The following is a description of a gene set: studied in species Homo sapiens Genes containing one or more binding sites for (PRKDC) in their promoter regions (TSS -1000,+100 bp) as identified by GTRD version 20.06 ChIP-seq harmonization. from publication Yevshin I, Sharipov R, Kolmykov S, Kondrakhin Y, Kolpakov F (PMID 30445619) Human Gene Set: PRKDC_TARGET_GENES, and this is the list of marker genes: TCP11, LRPPRC, ATF7-NPFF, TARS2, MAF1, AKAP13 (A-kinase anchoring protein 13), STT3A, POLRMT (RNA polymerase mitochondrial), RGMB, OXSR1, RBM15, APTR, SHFL, PPFIBP1, ABCA7, AGPAT1, PTMA, SLC29A3, GYS1, PMF1-BGLAP, SLF2, ZNF77, NRL, DERL2, PLEKHH2, UNG, RAB40B, MPHOSPH8, IVD, DDX19B, ZNF726, ENSG00000275740, AXL, PROSER3, MON1B, EIF4A1, SP3, XPO1, HDAC11-AS1, FUT8, PNKD, ZDHHC12, PRR13, ZNF486, CREB3L3, MYH9, CDC23, DNAL4, SCAMP2, SLC25A42, MTHFD1, GLCE, NR3C2, AAMP, PC, DHRS3, PLCL1, GLCCI1, LMAN2, ZFHX3-AS1, HDGFL2, ZNF714, DOHH, WBP1, AMER1, UFD1-AS1, STPG1, PHTF2, SPAG7, CEP44, HDAC4 (histone deacetylase 4), ARHGEF9, METTL14, BAZ1B, PHYHIP, FKBP3, HNRNPUL1, EIF1AY, MIR6860, DBI, HEXIM2, SRPK1, TEPSIN, PHF14, SIX2, ZNF200, AP3M2, STXBP5-AS1, SRP19, MTOR, RNF5, LMBR1L, ZNF564, CDK5R2, MTRFR, DCAF15, TMEM53 (NCBI Gene Id 79639), NIPAL3, DCAF7, LINC02210, NLRP1, ZRANB3, HNRNPAB, UBFD1, TPM4, C22orf39, SLC39A1, PTPRM, MEGF9, FAM161A, DRC3, RAB8A, TOP2B, KDM2B, DRC12, DNAI3, ACTL6A, SUFU, ZBTB20, KDM6A, CIRBP, HSPA5-DT, ETV5, NAXD, PITX2, IL11RA, ANAPC5, SUN2, AHI1, WBP1L, CREBRF, TRAF2, TSACC, ZNF678, ANKZF1, PMEL, PDIA6, ERAP1, CEP57, MED7, METTL14-DT, LENG1, ID2, CYTH2, PMS1, TDRKH, THAP3, ZNF211, RAB11B-AS1, ORMDL1, SETD1A, MRTFA, ZNF423, NGDN, ANKHD1-DT, JPT1, ZNF687, TRPS1, C3orf18, VAMP1, ZNF587B, NLRX1 (NCBI Gene Id 79671), CCNB2 (cyclin B2), NOL4L-DT, STX5-DT, FYN, PER1, RELCH, NR6A1, ENSG00000255647, CHCHD2, GNAS-AS1, ZNF141, PPP2R5E, DOC2A, RFWD3, XAB2, EPB41, HGH1, HIRA, NFYC, PANK2-AS1, ANKRD11, SNX12, TMEM45A, LINC01972, ZMYM5, GLRX5, ZC3H6, TRIM9, CCT7, GATAD2A, IER5L, TRAFD1, BRPF3-AS1, CLSTN3, MTMR12, ADAMTS4, IRF2BP1, HSPB6, C10orf143, CCDC137, ZNF436-AS1, CDC25A, UBP1, ARHGEF1, DNAJB5-DT, DLGAP5, ZMYM2, NUP98, ACOT8, RNF34, SNHG10, FLAD1 (flavin adenine dinucleotide synthetase 1), SLC28A2-AS1, MACROD2, PRPF40A, SORT1, H2AZ2-DT, OSBPL3, PCNX3, DNAJC27-AS1, SPRYD3, PRR11, ABHD8, C5orf22, STIP1, PAF1 (NCBI Gene Id 54623), AFG2B, ZNF687-AS1, COQ7-DT, SNRNP25, LAPTM4A-DT (LAPTM4A divergent transcript), SWSAP1, PTPN1, TTC23, MEX3C, ZNF691-DT, ZNF174, GLS2, CDK2AP2, ZNF790-AS1, HSPA2-AS1, CDK16, RHPN1-AS1, ZNF626, SMIM2-AS1, ENSG00000261335, RUVBL1, OTUD5, ZNF493, KATNAL2, ZNF833P, YIF1A, AASDHPPT, PXMP4, RPL6, CAPSL, R3HDM1, ABHD2, EMC9, OTUB2, USF3, CEP89, NDUFA3, EFCAB11, COPE, BPGM, SPG7, HAPSTR1 (NCBI Gene Id 29035), TMEM60, LINC00642 (long intergenic non-protein coding RNA 642), CNOT1, GTF3C1, PGPEP1, CARS2, RPN2 (ribophorin II), TNRC6B, SNORD60, PDLIM4, HIBADH (3-hydroxyisobutyrate dehydrogenase), AKTIP, WBP11, KDM4B, H1-12P, ZSCAN20, HNRNPK, MAF, PPP1R13L, PRADC1 (protease associated domain containing 1), CDR2-DT, PPM1K-DT, FRMD5, GRB2, PDP2, RTTN, ARAF, JUP, OSBPL2, TMTC4, CREB3L2, ORC2, DCUN1D4, CBX5, GUCY1B1, UBE2C, ZDHHC9, PLEKHA8, SRXN1, AK2, COQ7, CHD8, TMX2, SERTAD2, DCAF4, ERCC1, SRGAP2C, LINC01535, H2AZ2, FAM117A, RPL18A, RAB11B, PCDH10-DT, KLHL25, SEL1L2, INMT, LTN1, GET3, UPRT (NCBI Gene Id 139596), CRYZL1, ATP6AP2, C12orf60 (NCBI Gene Id 144608), GPR158, PPP3CA, INCENP, GTPBP1, KCTD9, NCK1-DT, CCDC8, RBM27, C1QTNF6, CASTOR1, LINC00665, HNRNPLL, PWWP2A (PWWP domain containing 2A), COPZ1, PET100, ZNF799, ZDHHC5, EIF2AK3-DT, ZBTB3, STARD3NL, SP1, SLC37A4, LMTK2 (NCBI Gene Id 22853), UGP2, ZNF519, ZNF680, ANKS3, GOLIM4, SKA2, STAT3, SEC14L2, ZBTB38, PACSIN2, ZNF431, LRRC74B, SCAI, KMT5C, BCL2L1 (BCL2 like 1), MAP3K3, TCP1, ANKRD54, ALKBH7, SLC15A4, LCMT1-AS1, PLAC9P1, AMD1, NAIF1, NONO, YJU2, PRMT1, TRIM45, ENO1-AS1, ARMC6, MIR4479, ZNF691, HYCC1, ZNF875, SARNP, PABPN1, BUB3, ZNF154, C19orf81, DCAKD, PDXP-DT, BRCA1, TANGO2, TMEM160, SIRT1, TYW1B, ENSG00000275765, MFRP, NUMB, CANX, ZBTB7B, MIR638, HACL1 (2-hydroxyacyl-CoA lyase 1), SEPTIN9, ARMH1, RPS6KA5, ZDHHC24 (zinc finger DHHC-type containing 24), ZNF823, FAAP24, PER2, GATM, TESK2, ZNF443, ZNF143, DCAF11, TDRKH-AS1, ACTN3, PTPN11P3, RPLP0, CCDC61, ZNF682, FICD, SLFN5, SHKBP1, APBA3, COPS7B, FAM72B, RGMB-AS1, UBE2S, ZNF774, ENSG00000255240, KIF1B, PRPF8, CHAF1A (chromatin assembly factor 1 subunit A), PGAP2, HSPA2, TTLL5, KRT15, SLC46A3, OIP5-AS1, BCKDHA, PJA2, GNA15-DT, SNHG19, EIF2AK3, TOMM40L, MED29, ATP6AP1-DT, ENSG00000257732, GOLPH3L, RHCE (NCBI Gene Id 652552), FRYL, ZNF66, ITFG2, RNF20, PCP4L1 (NCBI Gene Id 654790), INPP5B, NMT1 (N-myristoyltransferase 1), SDC2, DNAJC14, MLH1, SEMA4B, MYH9-DT, GADD45B, ELN-AS1, TPCN1, VSTM2L, TRAF7, ZNF587, TBC1D10B, MYH10, CFAP157, TINAGL1, MYL11, C2orf76, BTD, SAMTOR (S-adenosylmethionine sensor upstream of mTORC1), FAM83D, ZNF776, HRAS, CREB3L4, LCMT1, HLTF, CYB5A, SNX32, VBP1, ABCB8, TSPAN15, ZNF788P, CNOT3, ERC2, BCAS3, ZNF442, CCT3, DDX39A, PLIN3, SLC2A1-DT, SLC41A1, UVRAG, ZNF44, SAFB, ANKRD27, ZNF695, P2RX6P, RAB5C, FKBP14, GPR108, C7orf50, ARVCF, ADGRB2, COQ8B, ZNF436, TLCD5, MSANTD4, INHBE, ATP5F1B, ANAPC15, ANKHD1, HSPA5, RAB3A, HMGN5, LINC02210-CRHR1, SSR4, STX7 (syntaxin 7), MRPL37, CAND1, DCTN4, CETN4P, KHSRP, KANK3, DNAAF8, KCNAB2, JPT2, ZFYVE21, ZC2HC1C (NCBI Gene Id 79696), LINC01572, ANKRD16, HNRNPA1, COPS4, ZNF91, KMT5A, TMEM161A, FBH1, PNPLA6, PSMB3, THUMPD3-AS1, CYP2R1, EARS2, RAB5B, PLCD1, ANP32E, INMT-MINDY4 (NCBI Gene Id 100526825), DAPK3, RSBN1L, SLC2A1 (NCBI Gene Id 6513), GDI2, NUBP2, H2AJ, OS9, TLE4, ING1, EIF1, KAT6B, ST6GALNAC6, PANK2, ITSN1 (intersectin 1), ITFG2-AS1, ABCD3, PDZD7, ID2-AS1, SFPQ, PRC1, GNAI2, MED30, ELMO2, YBX1, HDAC4-AS1, SETD5, CIC, TRAPPC11, SLC2A8, DROSHA, MDC1, ZNF654, ZNF718, HBP1, ACTR2, PDLIM7, IQCD, RGS9BP, DIAPH3, HDAC11, MTFR2, RSPH4A, RNU2-17P, XRCC3, ATF7, DNM2, CCNL2, ARL17B, FBXO24, ARID3A, OXR1, CHASERR, RELB, TCERG1, ORMDL2, HNRNPC, COX6B1, TCF3, BBS12, PLS3, EHBP1, ANP32A, GOT1-DT, NDUFAF8, ZNF143-AS1, ENSG00000224478, PXN-AS1, ZNF492, SSBP3, ENSG00000254531, TMEM198B, ASXL1, TMEM9, ATP6AP1, WDR45, PRKACA, EVI5L, KANTR, ALKBH5, SELENOI, MECP2, ARHGAP19, CCR10, HEXIM2-AS1, CDCA3, PIGN, SLC25A25, ERCC2, MSMO1, PDXP, ZNF441 (NCBI Gene Id 126068), ZSWIM1, SCAND2P, ENSG00000227218, PCLAF, MGRN1, MED19, PPM1B, TRIP10, ORC6, ZNF418, TCTN3, FAM76B, TOM1L2, STARD5, ABCA11P, RTN4, DYNLRB1, OXLD1, RFX2, NRXN2, DHX38, RNF6, PPP2R5A, WHAMM, FGD5-AS1, LINC00654, NFE2L1-DT, NCOA2 (nuclear receptor coactivator 2), GBF1, EPM2AIP1, ORAI3, ZNF732, ESR2, PDE6D, DNAJB5, NF2, EIF5 (NCBI Gene Id 1983), TUBB4B, RMI1, CETN3, VPS35, ADAMTSL4, HS3ST3B1, POLR3A, FXYD5, POLR3K, WDR81, ZNF724, STARD7, NEK6, NLK, POLR1G, SIM1, MCM3, TLE1, PTPRA, RAB40C, GOT1, FAM120AOS, BBX, PHYHD1, ZNF100, ZNF689, ROGDI, RPL36AL, CYB5RL, CCNG1, SLC25A28-DT, GTPBP6, PAIP2B, PMF1, SIN3A, ZNF721, PPP1R7, MPZL1, PGAP4, MIEF2, RWDD4, MIR22HG, NPHP4, GBA1LP, KDM4A, LETM2, CALR, SPC24, HPS4, ARL6IP6, RNF13, ATG9A, BTBD10, COPS3 (NCBI Gene Id 8533), CHD6, ITK, PKNOX1, ZSCAN18, RBM39, MAP3K11, MEAK7, TUBGCP6, ACTN1, NXT1, ZNF555, SP2, SHARPIN, NR2C2, RHPN1, SLC39A3, WFS1, G3BP1, H3C9P, PPIA, TRAPPC12-AS1, ARL4A, HIP1, FHIT, MGAT2, NFE2L1, KRT36, ZSCAN32, AKR1D1, MSL3, KBTBD3, MAML1, CENPA, USP5, TTBK2, ENO1, ZNF417, DUSP10, NCK1, FAM222B, ZNF814, ZNF837, IP6K1, MRPL20-AS1, ACTN1-DT, GRPEL1 (GrpE like 1, mitochondrial), SBDSP1, AKAP8L, DNAJC27, TNRC6B-DT, CTTNBP2NL, FMN1, CNTNAP1, SPATC1L, TMC3-AS1, COL5A2, LINC02926, RFX1, LDLRAP1, EXOSC5, ADGRF3, NFATC4, ZDHHC13, HNRNPL, LRCH4, RBM4, SLC25A19, CAPSL-DT, TDP1, GRK6, TMPOP2, DDX49, SCNN1D, ZSWIM4, MTHFD2, KXD1, SFXN5, FAM111B, ZNF552, SPSB3, LITAF, MAP2K3, ARL17A, MATCAP1, PLCG1, ANKHD1-EIF4EBP3, HAVCR2, WASF3, RUVBL2, RPUSD3, RBM15-AS1, ARHGAP19-SLIT1 (NCBI Gene Id 100533184), SLC25A28, NFATC2IP, BRPF3, HNRNPR, DPP3-DT, AP2A1, C14orf93, RALGPS1, RBMX, ZSWIM3, NDUFS2 (NADH:ubiquinone oxidoreductase core subunit S2), SFXN3, HMGCS1 (3-hydroxy-3-methylglutaryl-CoA synthase 1), DMPK, PASK, ENSA, PGD, SLC26A2, KANSL1, FAM76A, CDR2, HERPUD1, INTS3, AHCY, SNORD59A, DPM2, STK11, TOP2A, CDCA2, MIR4999, MACO1, IFT27, AARS1, MROH8, RNF4, RRBP1, LIPE-AS1, PRR15, NBR1, TIGD1, LIN37, ACYP1, CEP131, DAZAP2, TP53BP1, CTDSP1, MRPL28, TGFB1I1, SESN1, MRPL18, ZNF563, CGGBP1, PCDH10, TIMM44, PPM1K, MROH1, OSBP, GATAD2B